Given this list of marker genes ALDH9A1, CS (NCBI Gene Id 94822), ACO2 (aconitase 2), ALDH2, ACSS2, ALDH3A2, here is a description of the gene set: Human Gene Set: WP_FLUOROACETIC_ACID_TOXICITY Fluoroacetic acid toxicity studied in species Homo sapiens